The following is a description of a gene set: from publication Weber M, Hellmann I, Stadler MB, Ramos L, Pääbo S, Rebhan M, Schübeler D (PMID 17334365) To gain insight into the function of DNA methylation at cis-regulatory regions and its impact on gene expression, we measured methylation, RNA polymerase occupancy and histone modifications at 16,000 promoters in primary human somatic and germline cells. We find CpG-poor promoters hypermethylated in somatic cells, which does not preclude their activity. This methylation is present in male gametes and results in evolutionary loss of CpG dinucleotides, as measured by divergence between humans and primates. In contrast, strong CpG island promoters are mostly unmethylated, even when inactive. Weak CpG island promoters are distinct, as they are preferential targets for de novo methylation in somatic cells. Notably, most germline-specific genes are methylated in somatic cells, suggesting additional functional selection. These results show that promoter sequence and gene function are major predictors of promoter methylation states. Moreover, we observe that inactive unmethylated CpG island promoters show elevated levels of dimethylation of Lys4 of histone H3, suggesting that this chromatin mark may protect DNA from methylation. Germline-specific genes with intermediate-CpG-density promoters (ICP) that are methylated in primary fibroblasts. Human Gene Set: WEBER_METHYLATED_ICP_IN_FIBROBLAST studied in species Homo sapiens, and this is the list of marker genes: ELOA2, H2BC1 (H2B clustered histone 1), TEX12, PRM2, POTEA, DDX4, PDHA2, LDHC, TDRD1, ACTL7B, TSSK2, ADAM2, CTCFL, PPP3R2, ADAM18, PRAME, TUBA3C, H1-6, ANKRD7 (ankyrin repeat domain 7), RNF17, PRSS21